Given this list of marker genes MAPKAPK2, KRAS, SHC2, MAPKAPK3, SHC3, SHC1, SRC, RALB, NGF, NRAS, MAPK13, MAPK11, SOS1, MAPK12, HRAS, NTRK1, GRB2, RALGDS, RALA, MAPK14, here is a description of the gene set: species: Homo sapiens part of: Signalling to ERKs Reactome Pathway: Signalling to RAS Signalling through Shc adaptor proteins appears to be identical for both NGF and EGF. It leads to a fast, but transient, MAPK/ERK activation, which is insufficient to explain the prolonged activation of MAPK found in NGF-treated cells.